The following is a description of a gene set: Mouse Gene Set: GOBP_POSITIVE_REGULATION_OF_LYASE_ACTIVITY species: Mus musculus Any process that activates or increases the frequency, rate or extent of lyase activity, the catalysis of the cleavage of C-C, C-O, C-N and other bonds by other means than by hydrolysis or oxidation, or conversely adding a group to a double bond., and this is the list of marker genes: Calcr, Raf1, Stim1, Orai1, Ftmt, Nf1 (NCBI Gene Id 320618), Adcyap1, Adcy3, Adora2b, Calca, Adcy1, Nos3, Lhcgr, Adcy2, Adcy7, Adcy4, Cacna1c, Acr, Fxn, Cacna1d, Iscu, Gnal, Drd1